Given this list of marker genes Msrb2, Fn3k, Msrb3, Fn3krp, Msrb1, Park7, here is a description of the gene set: species: Mus musculus Mouse Gene Set: GOBP_PROTEIN_REPAIR The process of restoring a protein to its original state after damage by such things as oxidation or spontaneous decomposition of residues.